Given this list of marker genes SLC18A1, SLC22A1, ACTB, SLC6A3, SLC29A4, SNCA, SLC22A2 (NCBI Gene Id 6582), SLC6A2, SLC22A3, here is a description of the gene set: Human Gene Set: GOBP_NOREPINEPHRINE_UPTAKE species: Homo sapiens The directed movement of norepinephrine into a cell, typically presynaptic neurons or glial cells. Norepinephrine (3,4-dihydroxyphenyl-2-aminoethanol) is a hormone secreted by the adrenal medulla and a neurotransmitter in the sympathetic peripheral nervous system and in some tracts of the CNS. It is also the biosynthetic precursor of epinephrine.